Given this list of marker genes Dis3l2 (NCBI Gene Id 77551), Wrn, Rexo4, Trir, Pold1, Cnot8, Trex2, Rexo2, Nme1, Trex1, Nme8, Cnot2, Tatdn1, Apex2, Mre11a, Exd2, Aplf, Pde12, Usb1, Xrn2, Pnldc1, Nme5, Dis3l, Cnot7, Exosc10, Cnot6l, Helz2, Myg1, Pan2, Eri2, Toe1, Pole, Rad9a, Pan3, Dis3, Apex1, Cnot6, Eri1, Pnpt1, Polrmt, Cnot1, Rad50, Nme7, Polg, Isg20l2, Exd1 (exonuclease 3'-5' domain containing 1), Eri3, Isg20 (interferon-stimulated protein), Meiob, Parn, Noct, Rad1, here is a description of the gene set: species: Mus musculus Catalysis of the hydrolysis of ester linkages within nucleic acids by removing nucleotide residues from the 3' end. Mouse Gene Set: GOMF_3_5_EXONUCLEASE_ACTIVITY